Given this list of marker genes Ctss, Itgae, Chil3, Ly6a, Rbpj, Znrf1, Ctla2a, Ctla2b, Adgrg1, Isg20, Ddit4, Zranb2, here is a description of the gene set: Genes up-regulated in the influenza-specific CD8+ T lymphocytes from bronchoalveolar lavage (BAL) compared to those from spleen. Mouse Gene Set: MARSHALL_VIRAL_INFECTION_RESPONSE_UP species: Mus musculus from publication Marshall DR, Olivas E, Andreansky S, La Gruta NL, Neale GA, Gutierrez A, Wichlan DG, Wingo S, Cheng C, Doherty PC, Turner SJ (PMID 15831586) The restriction of influenza A virus replication to mouse respiratory epithelium means that this host response is anatomically compartmentalized, on the one hand, to sites of T cell stimulation and proliferation in the secondary lymphoid tissue and, on the other hand, to the site of effector T cell function and pathology in the pneumonic lung. Thus, it is hardly surprising that virus-specific CD8(+) T cells recovered by bronchoalveolar lavage (BAL) from the infected respiratory tract seem more activated in terms of both cytolytic activity and cytokine production than those cells isolated from the spleen. The present analysis uses Affymetrix microarray technology to compare profiles of gene expression in these two lineage-related, yet anatomically separate, lymphocyte populations. Ninety differentially expressed genes were identified for influenza-specific CD8(+)D(b)NP(366)(+) T cells obtained directly ex vivo by BAL or spleen disruption, with nine genes being further analyzed by quantitative, real-time PCR at the population level. Integrin alphaE, for example, was shown by Affymetrix and real-time mRNA analyses and then by single-cell PCR and protein staining to be present at a much higher prevalence on the BAL CD8(+)D(b)NP(366)(+) set. The unpredicted finding, however, was that mRNA expression for 75% of the genes was lower in T cells from the BAL than from the spleen. Apparently, the localization of virus-specific CD8(+) T cells to the site of virus-induced pathology is associated with a narrowing, or focusing, of gene expression that favors enhanced effector function in the damaged, high-antigen load environment of the pneumonic lung.